Given this list of marker genes NF1, IDH2, RRAS, BMERB1, CERS2, STAP1, ATP1B2 (NCBI Gene Id 482), here is a description of the gene set: Human Gene Set: GOBP_NEGATIVE_REGULATION_OF_GLIAL_CELL_MIGRATION studied in species Homo sapiens Any process that stops, prevents or reduces the frequency, rate or extent of glial cell migration.